Given this list of marker genes IL18, GLIPR1, ENTPD1, SKAP2, CD36, CREG1, LY96, IL13RA1, RNASE2, FCGR2A, QPCT, CLEC4A, CD302, IRAK3, LILRA6, LAMP2, CSF2RA, CSF2RB, NCF2, here is a description of the gene set: Human Gene Set: FULLER_PBMC_F_TULARENSIS_VACCINE_LVS_AGE_22_54YO_18HR_TO_48HR_EARLY_UP The live vaccine strain (LVS) of Francisella tularensis is the only vaccine against tularemia available for humans, yet its mechanism of protection remains unclear. We probed human immunological responses to LVS vaccination with transcriptome analysis using PBMC samples from volunteers at time points pre- and post-vaccination. Gene modulation was highly uniform across all time points, implying commonality of vaccine responses. Principal components analysis revealed three highly distinct principal groupings: pre-vaccination (-144 h), early (+18 and +48 h), and late post-vaccination (+192 and +336 h). The most significant changes in gene expression occurred at early post-vaccination time points (<=48h), specifically in the induction of pro-inflammatory and innate immunity-related genes. Evidence supporting modulation of innate effector function, specifically antigen processing and presentation by dendritic cells, was especially apparent. Our data indicate that the LVS strain of F. tularensis invokes a strong early response upon vaccination. This pattern of gene regulation may provide insightful information regarding both vaccine efficacy and immunopathogenesis that may provide insight into infection with virulent strains of F. tularensis. Additionally, we obtained valuable information that should prove useful in evaluation of vaccine lots as well as efficacy testing of new anti-F. tularensis vaccines. from publication Fuller CL, Brittingham KC, Porter MW, Hepburn MJ, Petitt PL, Pittman PR, Bavari S (PMID 17349694) Genes up-regulated in peripheral blood mononuclear cell (18 to 48)h vs 0h in adults (22-54) after exposure to F. tularensis vaccine LVS, time point 18 to 48H. Comment: Pattern 6, up early studied in species Homo sapiens